Given this list of marker genes ZNF254, PGM3, GGCX, DNAL1, MSANTD3-TMEFF1, SRD5A3, MAGI3, SEC23A, ARFIP1, WNT3, SLC10A2, PSMC6, ADAMTS5, NCKAP1, SERINC5, TPM1, CHAMP1, RNF2, USPL1, UBE2K, IPCEF1, MOB3B, NF1, SPRTN, AFAP1L2, TLL2 (tolloid like 2), SLC25A31, MON2, TOB1, FUNDC1, FNDC3A, TTC33, DACH2, CTNND2, IRS1, DCAF4L1, DAZAP1, BBS5, CNOT6L, OMD, PPP1R1C, CHST11, ADAMTSL1, KLHDC1, MARF1, AP1G1, PDGFRA, CMPK1, NDFIP2, ZYG11B, SMARCAD1, CCP110, SMAD2, A1CF, TNS1 (NCBI Gene Id 7145), BBX, PLAGL1, ZNF597, ELK4, EPHA4, GPHN, MAGEE2, ZNF485, PRKG2, NLK, GABRA4, SRGAP1, ATG4C, SOX6, DGKH, FGFR1OP2, ATP2C1, PABIR3, F11R, BROX, GALNT13, DTX3L, SLF2, ANK2, CNTN5, DCAF4, MAP3K7, GSDMC, TMEM218, PWWP2A, MTMR6, LRRC28, PSD3, DMXL1, GABRG1, MAFG, CCDC62, MITF, STEAP4, CEMIP2, LIN7C, EGLN1, NCL, TMEFF1, LYN, RAB14, ANKRD30B, FAT2, HERPUD2 (NCBI Gene Id 64224), SMIM13, EMCN, KIF18A, PPHLN1 (NCBI Gene Id 51535), NUCKS1, SRSF2 (serine and arginine rich splicing factor 2), NFRKB, SLC1A3, CAVIN2, CDKN1B, GTF2A1, TLE4, DYM, SEMA5B, PGR, PHF3, RAPGEF5, FER, AGFG1, SLU7, AAK1, ZMAT3 (zinc finger matrin-type 3), GAD1, BORCS7, KCNV1 (NCBI Gene Id 27012), ZNF670, CD2AP, RIMOC1, GASK1B, CRKL, UBL3, CDK6, EHMT1, LCLAT1, EML6, B3GNT5, EXPH5 (exophilin 5), PDS5A, ZNF17, ZNF91, NR3C1, RMND5A, EFCAB14, DOCK3, COQ2, HECTD2, MINDY3, RGL1, ATRNL1 (attractin like 1), UPF3A, PALM2AKAP2, TRIP11 (thyroid hormone receptor interactor 11), FBXW11, SAMM50, ALCAM, ZMYND11, SPPL2A, AEBP2, FAM174A, AASDH, ZNF800, KLHL28, MGAT4A (NCBI Gene Id 11320), ROBO2, KANSL2, FAM135A, PRRX1, SMAD3 (NCBI Gene Id 51521), LRR1, EPC2, CBX5, SEMA3D, CLDN12, SNX30, TLL1, PNISR, PDE10A, RAP2B, INSIG2, CDCA7L, FMR1, KLHL32, PDP1, JMJD1C, FAM110C, MEX3B, PLAGL2, PPM1A, LAMP2, FZD3, XPNPEP3, POMP, FAM168B, ATXN7, BMP2K, CISD2, IGDCC3, PLXDC1, ATRX, here is a description of the gene set: Genes predicted to be targets of miRBase v22 microRNA hsa-miR-302b-5p in miRDB v6.0 with MirTarget v4 prediction scores > 80 (high confidence targets). species: Homo sapiens Human Gene Set: MIR302B_5P from publication Chen Y, Wang X (PMID 31504780)